Given this list of marker genes SH3RF1, MAPK9, HSPBP1, USP5, IL33, NFE2L2, FBXW8, CBFA2T3, SGTA, PLK1, PLK3, RNF139, DVL1, FZR1, IKBKG, DNAJB2, CHFR, ZER1 (NCBI Gene Id 10444), BCAP31, CDK5RAP3, FBXW7, PSMD10, BAG2, ZFAND2A, GSK3A, AURKA, CAV3, L3MBTL3, SOCS5, AKT1, CLU, SUMO1, HECTD1, PRICKLE1, ATXN3, PABIR1, MTOR, GSK3B (NCBI Gene Id 2932, glycogen synthase kinase 3 beta), LAPTM5, RBX1 (NCBI Gene Id 9978), CSNK1A1, AGBL4, HERPUD1, KLHL40, PRKN, HSPA1A, SUMO2, BBS7, ZYG11B, KEAP1, PTK2B, RFPL1, SIRT2, HAMP, HSPA1B, TRIM67, RNF180, ELOB, PAQR3, CCDC22, DISC1, SOCS4, STUB1, SMAD7, GBA1, TRIB1, COP1, PTK2, TRIB2, EGF, CSNK1D, PYHIN1, RCHY1, GCLC, FBXO22, SMURF1, CDC20B, DDRGK1, RAD23A (NCBI Gene Id 5886), TGFB1I1, CEBPA, TRIB3, AXIN1 (axin 1), LRRK2, TRAF7, RACK1, CDC20, SH3RF2, DET1, DAB2, AGTPBP1, NKD2, NUB1, GABARAP, NOP53, SIRT6, SH3RF3, PSEN1, TF, DDA1, VCP, MDM2, CSNK1E, AXIN2, TAF1, PIAS1, SIRT1, PTEN, here is a description of the gene set: studied in species Homo sapiens Human Gene Set: GOBP_POSITIVE_REGULATION_OF_UBIQUITIN_DEPENDENT_PROTEIN_CATABOLIC_PROCESS Any process that activates or increases the frequency, rate or extent of ubiquitin-dependent protein catabolic process.